Given this list of marker genes SFRP2, VANGL2, SFRP1, PKHD1, JHY, SAPCD2, SEC24B, here is a description of the gene set: Human Gene Set: GOBP_REGULATION_OF_ESTABLISHMENT_OF_PLANAR_POLARITY Any process that modulates the rate, frequency or extent of the establishment of planar polarity, the coordinated organization of groups of cells in a tissue, such that they all orient to similar coordinates. species: Homo sapiens